Given this list of marker genes KIT, XPNPEP2, DNASE1L3, ANGPT1, KNG1, PLCG2, CPN1, SPINK5, HS3ST6, PLG, MYOF, F12, SERPING1, here is a description of the gene set: Rapid swelling (edema) of the dermis, subcutaneous tissue, mucosa and submucosal tissues of the skin of the face, normally around the mouth, and the mucosa of the mouth and/or throat, as well as the tongue during a period of minutes to several hours. The swelling can also occur elsewhere, typically in the hands. Angioedema is similar to urticaria, but the swelling is subcutaneous rather than on the epidermis. Angioedema Human Gene Set: HP_ANGIOEDEMA species: Homo sapiens